Given this list of marker genes Chd7, Nrg3, Serpine2, Git1, Glud1, Nrp2, Dvl3, Llgl1, Btg2 (BTG anti-proliferation factor 2), Rbbp7, Shank3, Npy, Mast1, Akirin2, Pou3f3, Id4, Emx1, Apod, Fez1, Avpr2, Sema6b, Tacc3, Sdf4, Stk36, Dnaaf3, Ptpn11, Mgarp, Pex13, Kcne1, Sfrp2, Hes5, S1pr1, Pax4, Tsc1, Mapk1, Sema6d, Aspm, Anapc7, Atf2, Ak7, Tgfbr2 (transforming growth factor, beta receptor II), Cdk5r2, Nme5, Rtn4rl1, Bnip3, Sec24b, Rogdi, Elavl4, Specc1l, Ndel1, Slit1, Jhy, Src, Ttc8, Htt, Bbs2, Kat2a, Kdm1a, Ncam1, Lypd6, Atg7, Cacna1a, Kcna2, Sez6, Slc6a4, Hydin, Ift172, Lhx3, Apaf1, Naglu, Sphk2, Hoxb1, Phactr1, Pals1, Psen2, Pou1f1, Epha5, L1cam, Wnt1, Bcl2, Eml1, Grin1, Ppp1r9b, Tbr1, Pdgfra, Atrn, Arx, Ndst1, Abl2, Sox15, Adgrg1, Lrp8, Mir376a, Phf8, Plxnb2, Sez6l2, Nanos1, Tbx19, Atoh1, Gsx1, Gbx2, Dscaml1, Rax, Sec1 (NCBI Gene Id 56546), Atf5, Spef2, Pbx4, Fgf2, Ngf, Lef1, Epor, Sox9, Ptf1a, Adcyap1, Tal2, Wnt7a, Pou3f4, Bloc1s6, Zic1, Tacc2, En1, Utp3, Trp53, Lhx1, Kif1a, Brinp1, Hnrnpk, Nkx2-6, Dlx1, Fat4, Inhbb, Socs7, Il11ra1, Cwh43, Fancd2, Bcr, Aplp1, Esr2, Sox11, Faim2, Gpr37l1, Bcan, Ednra, Mir429, Dbi (diazepam binding inhibitor), Dkk1, Asph, Syne2, Mas1, Duox2, Mme, Mafb, Scx, Clp1, Hspa5, Zfand5, Oxtr, Atp2b4, Nr4a2, Slc4a7, Twsg1, Dcx, Pcnt, Gpr158, Ext1, Nlgn4l, Gsk3b, Filip1, Pomk, Hspg2, Zeb2, Vax1, Sfrp1, Cend1, Dnajc30, Shroom2, Wnt5a, Kras, Tyrobp, Pcm1, Ihh, Fbxo45, Prickle1, Six1, Ccdc134, Aldh1a3, Neurog2, Bmpr1a, Tiparp, Foxg1, Coro1c, Bmp4, Plxna1, Gas8, Mnat1, Nrg1, Kcnc1, Drd2, Ptchd1, Smg9, Cxcr4 (NCBI Gene Id 12767), Pax6, Cplane1, Cd3e, Pantr2, Cdon, Rpgrip1l, Nes, Secisbp2, Bglap2 (bone gamma-carboxyglutamate protein 2), Atrx, Egf, Fezf1, Tubb2b, Ikzf1, Mks1, Stil (NCBI Gene Id 230631), Sun1, Th, Trnp1, Wnt3, Mkks, Hap1, H2aj, Ogdh, Ttn, Nr2e1, Pitx3, Aatk (apoptosis-associated tyrosine kinase), Eif2b5, Tfap2a, Macroh2a2, Sct, Rnf7, Cul5, Aplp2, Cckar, Ncoa1, Sstr3, Gnpat, Lpar1, Tubgcp2, Grid2, Prop1, Stra6, Lmx1b, Ptprs, Fgf10, Nf1, Ints15, Wdr62, Rhoa, Rbpj, Afdn, Coq8b, Cnp, Anxa3, Ppt1, Emx2 (NCBI Gene Id 13797), Tfap2c, Mtpn, Pex5 (NCBI Gene Id 19305), Pax9, Pafah1b1, Fzd4, Mir200c, Arid1a, Pfdn1, Slc1a2, Robo2, Crispld1, Braf, Smarca1, Phox2a, Mir9-1, Itga4, Selenop, Ccdc32, Lhx6, Grcc10, Ncoa6, Foxb1, Fyn, Ubb, Med1, Ccdc141, Fktn, Csf1r, Nfix (NCBI Gene Id 18032), Large1, Plekha1, Mir141, Hdac2, Uba6, mt-Co1, Fancc, Stxbp3, Nsun5, Pak1, Rrm1, Anp32b, Tyro3, Plxna4, Atp1a3, Zbtb18, Slit2, Kirrel3, Afg2a, Fut10, Septin4, Dock7, Unc5c, Amigo3, Bmi1, Axin1, Pygo2, Cntn2, Cxcr2, Abl1, Aim2, Isl1, Gnaq, Lhx5, Tgfb3, Wnt7b, Sema4c (sema domain, immunoglobulin domain (Ig), transmembrane domain (TM) and short cytoplasmic domain, (semaphorin) 4C), Olig2, Dll1, B4galt2 (NCBI Gene Id 53987), Igf1 (insulin-like growth factor 1), Cntn4, Lamb1, Wdr37, Pitx2, Ephb1, Smarcc2, Tulp3, Mmp14, Rara, Mecp2, Sphk1, Chrd (NCBI Gene Id 12667), Csrnp1, Ankrd11, Otx2, Ufc1, Meis2, Ndufs4, Efhc1, Fgf8, Bbs7, Hspa8, Cep290, Xrn2, Dab2ip (NCBI Gene Id 98996), Ncstn, Notch3, Atic, Odad3, Pbx1, Gdf7 (growth differentiation factor 7), Kif14, Sox1, Klhl1, Otx1 (orthodenticle homeobox 1), Nrxn1, Htr6, Igf1r, Prkg1 (protein kinase, cGMP-dependent, type I), Cic, Cdk5rap2, Mfsd2a, Dmrta2, Dync2h1, Zswim6, Srd5a2, Gsx2, Ezh2, Tsku, Tmem67, Dixdc1, Met, Arhgap32, Frs2, Uqcrq, Nr2f1, Rapgef2, Lrp2, Abcc1, Creb1, Zeb1, En2, Grhl2, Gli2, Mecom, Uncx, Hes3, Nfib, Flvcr1, Nefl, Kcna3, Phox2b, Flrt3, Col3a1, Slc7a11, Inhba, Gak, Scrib, Plxna3, Atxn1l, Prkdc, Nr2f2 (nuclear receptor subfamily 2, group F, member 2), Col2a1, Mmp2, Zfp423 (NCBI Gene Id 94187), Mink1, Amigo2, Vps51, Pomt2, Pax5, Slc4a10, Atp1b2, Nipbl, Git2, Nnat, Rab3gap1, Svbp, Psen1, Setd2, Rarb, Tubb2a, Setd1a, Cbln1, Sez6l, Hhex, Cited1, Flna, Tuba1a, Psap, Plxna2, Cln5, Mir124a-1, Ophn1, Rarg, Crtac1, Aqp1, Prdm13, Pcsk1, H2ax, Hdac1, Zdhhc16, Bglap, Hesx1, Sstr2, Ulk4, Hoxb3, Nrp1, Fzd3, Ldb1, Eef1ece2, Maco1, Hsd17b7, Pdss2 (prenyl (solanesyl) diphosphate synthase, subunit 2), Fut1, Atat1, Itgb1, Arcn1, Foxj1, Pten, Tra2b, Mir200a, Rbfox2, Arl6, Kif26a, Celsr2, Mir9-2, Gabrb3, Crh, Prdm8, Prox1, Nars1, Pomgnt1, Zfp640, Upf3b, Rtn3, Sall3, Foxo3, Brca2, Ctns, Celf1, Mdk, Col4a1, Zfp335, Kdm4b, Fbxo41, Kdm7a, Dmxl2, Dmd, Rtn4, Gria1, Slc23a1, Sall1, Egfr, Whrn, Shroom4, Vax2, Arid5b, Dlx2 (distal-less homeobox 2), Nfasc, Pou3f2, Raf1, Gata2, Dlg5, Scyl2, Ski, Avpr1a, Tbx3, Ephb2, Fcgr2b, Rfx4, Slc1a1, Ncor1, Dclk2, Ier3ip1, Tacc1, Ep300, Rtn4rl2, Chd8, Htra2 (HtrA serine peptidase 2), Numb, Kcnq2, Hif1a, Amigo1, Ncor2, C2cd3, Meis3, Nf2, Bag6, Hoxb2, Agtr2 (angiotensin II receptor, type 2), Tgfb1, Zfp365, Sin3a, Rab18, Ulk1, Hnf1b, Dlc1, Crkl, Arl13b, Efna2, Slc32a1, Btbd3, Lrrk2, Myh10, Itgam, Ddit4, Neurod6 (NCBI Gene Id 11922), Six3, Gdpd5 (NCBI Gene Id 233552), Akna, Sox6, Tfap2d, Sun2, Map2k1, Noto, Fgfr2, Usp9x, Ccdc39, Immp2l, Lhx2 (NCBI Gene Id 16870), Dab1, Ssbp3, Pitx1, Pou3f1, Fgfr1, Slc6a17, Rtn2, Mcph1, Fkrp, Casp3, Nkx2-1, Herc1, Mir200b, Dpcd, Kcnc2, Slc25a46, Smarca4, Zfp950, Bmp7, Nodal, Tmx2, Bax (NCBI Gene Id 12028), Eomes, Mettl14, Nr2c2, Kcna1, Mir9-3, Ptch1 (patched 1), Szt2, Slc2a1, Epha7, Tmem108, Chrnb2, Bmp5, Atxn2, Atp7a, Robo1, Sema3e, Ntrk2, Meis1, Erbb4, Atg16l1, Notch1, Hnrnpd, Sema7a, Kif21b, Vps13b, Pou4f1, Dicer1, B3glct, Hprt1, Zic3, Map1s, Il11ra2, Nog, Schip1, Cdk5, Slc6a3, Csnk2a1, Fgfr3, Wnt2, Comt, Cep120, Dmbx1, Macrod2 (NCBI Gene Id 73752), Uchl5, Csnk1d, Spag6l, Ttll1, Gpx4, Bptf, Hoxa1, Abcb6, Lmx1a, Atp6ap2, Neurog3, Dlx5, Nhlh2, Hmga2, Tbc1d23, Xrcc1 (NCBI Gene Id 22594), Magee2, Ptger3, Samd4b (sterile alpha motif domain containing 4B), Msx1, Cntnap2, Rere, Neurod2, Axl, Sstr1, Kif27, Hook3, Il11ra3, Pianp, Fzd6, Bhlhe22, Gdf10, Pax2, Ugp2, Wdr89, Crispld2, Tox, Fezf2, Sptbn2, Tctn1, Flvcr2, Sox21, Smo, Kif3a, Rac3, Odad4, Barhl1, Cdk5r1, Kndc1, Diaph1, Kdm2b (lysine (K)-specific demethylase 2B), Wnt2b, Bbs1, Ghrhr, C5ar1 (complement component 5a receptor 1), Neurod1, Tnr, Rtn4r, Chd5, Gba1, Mboat7 (NCBI Gene Id 77582), Numbl, Sema5a, Wnt9b, Ift88, Rora, Cdh2, Ak8, Ghrh, Wdr11, Lhx8, Wls, Igf2bp1, Ctnnb1, Kat6a, Foxa2, Lrp6, Plcb1, Rac1, Kdm6b, Gas1, Slc38a2, Hoxa2, Cxcl12, Atp1a2, Ascl1, Srgap2, Cdk2ap1, Qars1, Pbx2, Sox14, Mapk3, Skor2, Gart, Neurog1, Psmg1, Sox2, Aldh1a2, Twist2, Bmerb1, Mdga1, App, Fabp7, Sos1, Nde1, Top2b, Otp, Ddx10, Tcf7l2, Arhgap35 (Rho GTPase activating protein 35), Smad9, Mrtfa, Agtpbp1, Draxin, Gli1, mt-Nd4, Dhx37, Ccdc85c, Egr2, Tbx1, Ndnf, Abat, Cx3cr1, Rbbp4, Shh, Bcl11b (NCBI Gene Id 78682), Ctnna2, Gli3, P2ry12, Aars1, Gmppa, D16Ertd472e, Myo16, Sox3, Atm, Napa, Slitrk5, Negr1, Id2, Fxr1 (NCBI Gene Id 99741), Reln, Dct, Foxp2, Atp2b2, D130043K22Rik, Ttc21b, Cbs, Pbx3, Bbs4, Ryk, Dclk1, Hmx2, Cfap43, Trp73, B2m, Disc1 (NCBI Gene Id 640053), Fxr2, Mapk8ip3, Sox4, Diaph3, Ufm1, Nr4a3, Alk, Wdr47, Mettl3, Limk2, Abr, Col1a1, Scn2a, Zmiz1, Akt3, Ywhae, Bmp2, Gsc, Trappc9, Srf, Sgpl1, Rtn1, Wnt4, Matcap1, Smad1, Sema3a, Dnah5, Pgap1, Rras, Wnt3a, Hmx3, Nin, Dlx6, Map2k2, Hes1, Atxn1, Osr2, Htr5a, Irs2, Foxr1, Crk, Fbxw11, Fos, Fgf13, Cers1, Ntf3, Mrtfb, Ephb3, Ttbk2, Odad2, Knl1, Sox12, Drd1, Cntn1, Foxc1, Nme7, Pcdh18, Pfas, Arnt2, Crebbp, Arsb, Tgfb2, E2f1, Zic5, Bsx, here is a description of the gene set: Mouse Gene Set: GOBP_HEAD_DEVELOPMENT studied in species Mus musculus The biological process whose specific outcome is the progression of a head from an initial condition to its mature state. The head is the anterior-most division of the body.